Given this list of marker genes BLNK, AGFG1, ZNF277, STRN3, RUSC1, ZFP36L2 (ZFP36 ring finger protein like 2), POLR1HASP, COX11, GLE1, IARS2, HSPA4, ZMYND11 (NCBI Gene Id 10771), DUS2, FCER2, GRAP, OSBPL10, RSF1, CD72, MORC1, ANGEL1, PCOLCE2, CDC14A, GRPR, MST1, CD24P4, TSPAN14, TM9SF4, SPIB, WSB1, KCNQ2, NUMA1, STAU2, ADD3, DNASE1L3, PAX3, PPP1R9A, ARFIP1, LUC7L (NCBI Gene Id 57202), EPB41, FABP4, PECR, AK2, PPP2R5D, MSR1, DLG3, IGHD, GIMAP5, SGSM3, CFAP45, EIF5A, SOS2, PRUNE1, ESR2, ADI1, CD22 (NCBI Gene Id 933), SLC15A2, VPREB3, UGCG, SLC7A6, CEACAM1, PDCL, ACVRL1, COBLL1, CR2, PBXIP1, FOXN2, INPP5B, FAM149B1 (NCBI Gene Id 317662), DBT, TMEM209, ATP2A3, RPL29, FGF1, ITM2B, ZEB1, SLC2A5, WASL, ALOX15 (arachidonate 15-lipoxygenase), HNRNPUL2, LRP12, POU3F4, MMRN2, FOXF1, CYP4F3, MRPL24, PFKM, GSN, ANXA9, PRKG1, RNGTT, TBC1D8B, CLDN15, BCL11A, BHMT, ZKSCAN1, CD19, GPR3, ENTREP1 (endosomal transmembrane epsin interactor 1), RPL22, HLA-DOB, FHL1, VPS8, CAPN3, CYP2R1, GLS, JPT2, CHRNA4, BANK1, CD79A, PSORS1C1, COL18A1, WASF1, SLC39A9, BLTP1, ANGPTL3, FGFR2, GDF11, PREPL, CES2 (NCBI Gene Id 8824), TAPBP, NIT2, TTC9, PCM1, IL1RAP, EIF2D, HDAC1, TNFRSF11B, SELPLG, CRIP2, PAWR, HTR3A, RPL32, CASP6, MRTFA, SFI1, CARF, MFF, SHC1, CD82, INHBA, MS4A1, IGKV1D-8, CATSPERZ, CHI3L1, RPL23, CLCN4, GPM6A, PKIG, EFCAB11, FCRL2, APC, TIA1, GPA33, RPS9, ATRX, GLRA3, GNB5, TMEM161A, SYNJ2, P2RY2, MZF1, MYH10, KIF2A, ZNF318, LGALSL, COL9A3, BDH1, EFCAB14, FMO5, TRIO, HIPK3, RALGPS2, DCC, VPS50, IGHV4-34, LSM4, N4BP2L2, CSF1, RAC2, here is a description of the gene set: from publication Ramilo O, Allman W, Chung W, Mejias A, Ardura M, Glaser C, Wittkowski KM, Piqueras B, Banchereau J, Palucka AK, Chaussabel D (PMID 17105821) Each infectious agent represents a unique combination of pathogen-associated molecular patterns that interact with specific pattern-recognition receptors expressed on immune cells. Therefore, we surmised that the blood immune cells of individuals with different infections might bear discriminative transcriptional signatures. Gene expression profiles were obtained for 131 peripheral blood samples from pediatric patients with acute infections caused by influenza A virus, Gram-negative (Escherichia coli) or Gram-positive (Staphylococcus aureus and Streptococcus pneumoniae) bacteria. Thirty-five genes were identified that best discriminate patients with influenza A virus infection from patients with either E coli or S pneumoniae infection. These genes classified with 95% accuracy (35 of 37 samples) an independent set of patients with either influenza A, E coli, or S pneumoniae infection. A different signature discriminated patients with E coli versus S aureus infections with 85% accuracy (34 of 40). Furthermore, distinctive gene expression patterns were observed in patients presenting with respiratory infections of different etiologies. Thus, microarray analyses of patient peripheral blood leukocytes might assist in the differential diagnosis of infectious diseases. Human Gene Set: GSE6269_STAPH_AUREUS_VS_STREP_PNEUMO_INF_PBMC_DN studied in species Homo sapiens Genes down-regulated in comparison of peripheral blood mononuclear cells (PBMC) from patients with acute infection: S. aureus versus S. pneumoniae.